Given this list of marker genes GRB2, HCK, NLK, PIK3R1, SOS1, PRKCD, TIMP1, STAT1, NCOA1, AGT, PRDM1, MAP2K2, MAP2K1, PIK3R2, SOCS3, JUNB, MAPK1, GSK3B, IL6, JAK1, BCL2L1, PTPN11, IL6ST, NR2F6, BAD, AKT1, RPS6KB1, GAB1, IL6R, STAT3 (signal transducer and activator of transcription 3), MAP3K7, TYK2, VAV1, MAP2K4, IRF1, HDAC1, RAC1, MAPK3, CRP, SHC1, VIP (NCBI Gene Id 7432), CREBBP, JAK2, here is a description of the gene set: species: Homo sapiens Human Gene Set: WP_IL6_SIGNALING IL6 signaling